Given this list of marker genes MBNL2, ZNF492, FLRT3, NFIL3, XRCC4, PARD6G, ATL2, NSD2, CERT1, SNX29, BICC1, OCLN, ZFAND5, ITGB1, ROR1, UBE2E3, TRAPPC10, ZNF678 (NCBI Gene Id 84841), CCDC80, TRIM24, C5orf63, SENP7, CANX, TYW5, MEPE, FMO5, SSB, TSPAN19 (NCBI Gene Id 144448, tetraspanin 19), C3orf80, KLHL24, WDR72, RILPL2, GPN3, SINHCAF, FRG2, KIF20A, ADM, EIF1B, KLF5 (NCBI Gene Id 688), ITGAV, TADA2B, ABCG2, PLCXD3, FNDC3B, GAS2L3, FERMT2, RPTN, SLC16A4, ARID2, CILK1, ARPP19, BAAT, RBL2, ZNF281, OCA2, RBM3, SLC16A7, KCTD4, TAF2, KRTAP4-8, GTF2F2, SYT4, ZNF521, CDK19, BLTP3A, PATZ1, KLF3, GTF2A1, EXOC1, MAP2K4, EPB41L2, EIF2S2, CCNG2, PPP4R3B, NEDD4, GTF2H1, STRN, NRG1, SRF, FAM174A, YIPF5, BPNT2, CFAP418, CPNE8, EIF3A, CCNYL1, JMY (NCBI Gene Id 23651), AFF4, PRKD1, FBXO45, GRM3, KHDRBS2, SENP6, HTR2C, TMTC2, MINDY2, PCDH18, SYT16, CYYR1, SAMD8, CHN2, AP1S3, UBN2, RGS4, KDR, SYCP2L, ADD1, RBM24, UBE4B, FZD4, TVP23B, POU2F1, TEX261, USP8, CHSY3, SYNJ1, RAB2A (RAB2A, member RAS oncogene family), VKORC1L1, KDELR2, ZNF711, MOB3B, DSG3, ZNF236, ATAD5, CDADC1, CSTA, USP43, DMD, TRIM5, WLS, MPRIP, IPMK, MAP4K4, CREBZF, ANKRD13C, SPOCK3, RIC1, FGD4, CEP350, PRRX2, EBF1, TMEM117, NF1, TMEM252, IL17A, APC, PCDH7, ZNF572, UBE2E2, FZD6, STK38L, PLPP3, ARID4B, BCL2L11, GPR162, RORA, ZNF503, CAPRIN2, CDH19, ATP13A3, NECTIN1, ATP5MC2, GNAI3, KALRN, KCNJ3, VEGFA, FNIP1, SASS6, METTL6, CHRNA9, FAM13C, DTD2, TRIM62 (NCBI Gene Id 55223), GAS1, SCAMP1, TOB1, ASCL1, C11orf58, CDK11B, CLCF1, RPRD1A, CAPZA1, CNOT6L, HORMAD1, GNPAT, KCNJ13, TBX18, DPH7, ZNF107, CEP135, APCS, VEGFC, PCYOX1, PACSIN3, PNISR, HOOK3, ACSL4, HIPK3, TMEM209, SNAPC1, PIGK, CNR1, B4GALT6, HEG1, ADD3, KCTD1, FMO2, DPH6, RAI1, PTP4A1, ZNF33A, GOLM2, IPO5 (importin 5), RAB29, C2orf69, FCHSD2, FNBP4, SOCS2, FBXL3, ADAM10, TBL1XR1, BOLL, SHPRH, NTNG2 (NCBI Gene Id 84628), ACLY, MTX3, WIPF1 (WAS/WASL interacting protein family member 1), PCDH19, CPSF6, WEE1, SBNO1 (strawberry notch homolog 1), SLC22A4, PNRC1, GPC6, C18orf32, C11orf87, NCOA1, SLC9C1, NFIB, HLA-G, PHF20L1, BMS1, ZMYND8, CPEB3, SMAD5, ZNF527, SIAH1 (NCBI Gene Id 6477), UBA6, GDI2, ZCCHC24, MACF1, NECTIN3, RNF111, ING2, DGKH (diacylglycerol kinase eta), CDK11A, ABHD13, NKRF (NCBI Gene Id 55922), CGGBP1, LRCH2, CEBPB, FRMD4A, GATB, FOXC1, APOBEC3A, RAB10, SCOC, LRP1B, TAOK1, CYP2C8, CCDC140, SRSF7, TAFA2, KRTAP4-11, INO80D, RNF44, RPS6KB1, CCDC85A, MAP4, LMBR1 (limb development membrane protein 1), LARP4B, TLE4, MTDH, TMX3, C8orf76, GPBP1L1, LNX1, AHDC1, CMTM8, CBFB, TAF1A, TSPAN7, TMEM263, SNRPB2, DCTN6, GXYLT1, MAGI2, UBE2K, EFR3A, FBXO30, TRIM49, IFNW1, HECTD2, NIPBL, SMC2, CLIC4, IKZF2, SESN3, SATB2, MBNL3, CEP43, ATG14, ZCCHC13, KCNC2, MBTD1, FEZF1, CHIC2, BTAF1, APOBEC3B, CCNK, ATXN1L, SF3A1, PRDX1, MARCHF6, TCF7L2, PRDM2, FSD1L, ZC3H13, HCN1, CREBRF, EFNA5, KPNA6, UBAP1, MCTP1, CASK, WASF2, PTPDC1, ACER3, SUSD5, MDM4, TOB2, DARS1, LMO4, UBXN8, EGR1, DOCK9, CDK2AP1, RNF13, CMTM4, GPR85, RABGAP1 (RAB GTPase activating protein 1), EP300, CALU, SESTD1, FRG2C, CTDSPL2, MITF, ARMC3, POU4F2, GNE, VWC2, MYF5, NUMBL, ADAMTS6, MOB4, ZMYND11, MAP4K2, ZEB1, UBIAD1, ATAD2, DDX3X, FRAS1, TRIM49C, FREM2, SCAI, PTTG1IP, PRPF4, BICD2, KLC1, TMOD3, RGS7, PBX3, CYFIP2, FAM76B, RNF217, FAM168B, SPECC1L, AEBP2, NAB1 (NGFI-A binding protein 1), CCT5, CAPZA2, SCAF11, RTN1, AGFG1, PHF21B, IL7, KCTD21, GMFB, SYDE2, HSPH1, CHIC1, NAP1L1, SLC33A1, LNPK, BHLHE22, KANK1, PHTF2, ZNF77, EAF2, TNPO1, LGALSL, SNRNP40, HMGCR, CFAP20DC, BPTF, GOLIM4, CDK17, STXBP5, DACH1, DENND1B, NUCKS1, SRSF5, LRRC32, here is a description of the gene set: species: Homo sapiens Genes predicted to be targets of miRBase v22 microRNA hsa-miR-655-3p in miRDB v6.0 with MirTarget v4 prediction scores > 80 (high confidence targets). Human Gene Set: MIR655_3P from publication Chen Y, Wang X (PMID 31504780)